Given this list of marker genes ABCA13, TOR1A, PPP3CC, PLAA, AP2M1, NLGN1, LRRK2, here is a description of the gene set: Human Gene Set: GOBP_POSITIVE_REGULATION_OF_SYNAPTIC_VESICLE_RECYCLING studied in species Homo sapiens Any process that activates or increases the frequency, rate or extent of synaptic vesicle recycling.